Given this list of marker genes H2-Aa, Prkcb (NCBI Gene Id 319718), Hsd11b1, Morf4l1, Caln1, Fos, Fbln1, Lin7a, Diras2, Ndufa4, H3f3b, Calb2, Scn2a, Krt14, Pcsk1n, Dpt, H2-D1, Snap25, Emc10, Neurod1, Zic2, Acta2, Mxra8, Micu3, Sqstm1, Cplx2, Abhd8, Rtn1, Cbln1, Gpm6a, Ubb-ps, Psap, Snhg11, Bsg, Atp6v0c, H2-K1, Atp5f1b, Ypel3, Prdx1, Dcn, Srrm2 (NCBI Gene Id 75956), Rbfox3, Aldoa, Ppp3ca, Hsp90ab1, Nrxn2, Rplp0, Meg3, Map1b, Adcy1, Jund, Ccn1, Mfap4, Malat1, here is a description of the gene set: studied in species Mus musculus Mouse Gene Set: TABULA_MURIS_SENIS_BRAIN_NON_MYELOID_INTERNEURON_AGEING from publication Tabula Muris Consortium (PMID 32669714)